The following is a description of a gene set: species: Homo sapiens Gait ataxia A type of ataxia characterized by the impairment of the ability to coordinate the movements required for normal walking. Gait ataxia is characteirzed by a wide-based staggering gait with a tendency to fall. Human Gene Set: HP_GAIT_ATAXIA, and this is the list of marker genes: RUBCN, GCH1, CUL4B, TCF4, CAMTA1, FERRY3 (FERRY endosomal RAB5 effector complex subunit 3), FDXR, SCN1A, CARS1, TBC1D24, SLC9A1, EBF3, IFRD1, TTBK2, ADSL, ATXN3, WWOX, HEXB, TBP, PPP2R1A, CLCN2, HPDL, AHDC1, SCN8A, SLC9A6, LMNB1, AQP4, DCPS, NAXD, GRID2, SLC25A4, ALDH18A1, AP2M1, IMPDH2, ERMARD, ACOX2, MECP2, PLD3, MT-ND1, MT-ND2, PIGG, RNU12, CWF19L1, BRAT1, TTC19, MT-ND3, TECPR2, ATP1A2, TWNK, MT-TW, DNAJC3 (NCBI Gene Id 5611), SCYL1, PEX16, DKK1, HERC1, STUB1, COQ4 (NCBI Gene Id 51117), TTI1, CIITA, COQ2, RAB11B, DEAF1 (DEAF1 transcription factor), HLA-DQB1, PRKN, GABRG2, PRX (NCBI Gene Id 57716), RRM2B, PIGL, AASS, TMEM240, SCO2, PRNP, ELOVL4, GTF2H5, LARS2, KIF1C, DNAJC6, MT-ND5, GABBR2, EIF2S3, PAK1, SQSTM1, SLC25A46, NAA80, GTPBP2, SACS, NOP56, NEFL, CP, TRPC3, RFX5, TBC1D2B, LETM1, LITAF, AP1S2, PPP1R15B, MORC2, DOCK3, PPP1R21, POLR3B, PCDH19, APTX, SCARB2, SIL1, PSAP, BSCL2, GRIN2A, ATP1A3, OGDH, MT-ND6, NTNG1, PDYN, NUP62, MT-TL1, NPC1, WDR26, BEAN1 (brain expressed associated with NEDD4 1), PNPLA6, FXN, MPZ, ERCC2, TSPOAP1, TMEM106B, SMC1A, VLDLR, CTBP1, TRAPPC6B, TMEM163, ARID1B, EIF2AK2, SCN1B, FAT2, TH, KCND3 (potassium voltage-gated channel subfamily D member 3), OPHN1, TARS1, GPAA1, ATXN8OS, VPS41, KCNC3, SCN2A, SPG7 (NCBI Gene Id 87549), ANO10, CAPN1, NR4A2 (nuclear receptor subfamily 4 group A member 2), CACNA2D2, NARS1, MT-ATP6, FBXO28, SYNE1, SPTBN2, MAB21L1, NUP54, ATN1, ATCAY, PEX10, FMR1, GRIA2, ARCN1, SMARCA2, LMNB2, IQSEC1, CTSF, ATXN10, UBTF, POLR1A, TRIO, SDHA, ADAR, PODXL, VPS51, RNF170, GJB1, MT-TK, PLA2G6, CCDC88C, REEP2, B9D1, GRM1, PMPCA, KDM5B, XRCC1, CAV1, PDP1, ERCC3, PRDX3, ENSG00000288330, SNRPN, LNPK, TPP1, PRKCG, FZR1, CACNA1A, GBA2, NUS1, UROC1, GABRA1, MTTP, NFU1, ARSA, HSD17B4 (hydroxysteroid 17-beta dehydrogenase 4), TEFM, RFXAP, FLVCR1, FA2H, SCN9A, CHAMP1, POLG, MME, CHMP1A, TPK1, NSUN2, GTF2E2, TANGO2, SYNJ1, VPS13D (NCBI Gene Id 55187), MARS2, THG1L, GRIK2, TGM6, PMP22, RFC1, PCNA, RFXANK, SLC19A3, MPLKIP (M-phase specific PLK1 interacting protein), ATAD3A, WDR81, CLN8, CDKL5, RPL10, AARS1, PPP2R5D, PRRT2, AFG3L2, POLG2, ABCB7, TPR, SETX, ATXN2, SH3TC2, ITPR1, ERBB3, POU3F4, EEF2, TUBB4A, MRE11, PEX6, RNF113A (ring finger protein 113A), MT-TV, CACNA1G, COA7, ABCA2, ELOVL5, FGF14, ATP13A2 (NCBI Gene Id 63919), MT-ND4, MAN2B1, UCHL1, PNPT1, PRDM13, UBA5, UBE3A, GDAP2, HTT, NAA20, MTPAP